The following is a description of a gene set: from publication Chen Y, Wang X (PMID 31504780) Human Gene Set: MIR4288 Genes predicted to be targets of miRBase v22 microRNA hsa-miR-4288 in miRDB v6.0 with MirTarget v4 prediction scores > 80 (high confidence targets). studied in species Homo sapiens, and this is the list of marker genes: VSTM2A, LINC03104, ADAM22 (NCBI Gene Id 53616), ACVR2B, ZC3HAV1, TCEANC2, TIGD6, KCNQ3, DCTN4, KIF1B, ITGBL1, PTCHD1, ZNF208, ZNF598, GFRA2, CAMK1D, AQP4, ELF3, POU2F1, SAXO1, IFT57, ZNF148, MGAM2, BMAL1, DENND4A, SMR3B, PARP8, PALD1, LIN9 (NCBI Gene Id 286826), ADAM10, TOX, FBXW11 (NCBI Gene Id 23291), ERI3, CCNL1, RUVBL1, CDH11, SHANK2, NRARP, ZNF552, DROSHA, NBPF9, RASL12, TNRC18, NTNG1, FAR2, NACC2, USPL1, SELENOK, ATG7, IKZF3, TRMT13, SH3PXD2A, ING3, TGFB2, KLF4, PSIP1, TAF6, SPRYD7, LINC03105, KCMF1, GGCT, TVP23C-CDRT4, CC2D1A, GPRIN3, NTM, SERTAD2, RASA1, ATG2B, LHX6 (NCBI Gene Id 26468), TMTC2, SP4 (Sp4 transcription factor), PRRG1, UGT8, ELAVL4, COLGALT1, CSNK2A1, PKDCC, SNRK, MAPK10, FGF7, ZFC3H1, AP1G1, ZNF382, CD40LG, SIX3 (SIX homeobox 3), MATCAP2, CCDC121 (coiled-coil domain containing 121), RNF125, DYRK1A, BCL6, DCN, MGAT5B, RFLNB, PKD1 (NCBI Gene Id 5310), CLVS1, PTPN13, ROR1, BCL11A, CEP350, ENSG00000277067, GLUL, UBXN4, SPC24, SHISA7, UHRF1, SOX5, SUCO, PTPN7, LRRC4C, LTBP2, NAA60, SORCS3, MAGI1, UIMC1, SULF1, AMELX, ZEB2, EPB41L1, PPARGC1B, KLF3, DLEU7, DNMBP (NCBI Gene Id 23268), LAPTM4B, CAPZB, MMP16, UBE2Q2, CCNT1, SCAMP4, LHPP, RAB39A, CASP14, ZNF576, TOMM6 (translocase of outer mitochondrial membrane 6), MYCT1, DCANP1, SALL3, TANK (TRAF family member associated NFKB activator), MEF2C, CDRT4, HILPDA, DHX40, LMX1B, SORBS1, SKAP2, PROK1, PABPC1L2A, CHST3, ZNF45, COLEC12, ORAI2, HOXC4, OAS2, GPR26, TEAD1, RALB (RAS like proto-oncogene B), CSNK1D, MBNL1